The following is a description of a gene set: Dysplasia of the femoral head species: Homo sapiens Human Gene Set: HP_DYSPLASIA_OF_THE_FEMORAL_HEAD The presence of developmental dysplasia of the femoral head., and this is the list of marker genes: MTX2, B3GALT6, TRAPPC2, HSPA9, IHH, COL2A1